The following is a description of a gene set: Binding to a neurotrophin p75 receptor. Mouse Gene Set: GOMF_NEUROTROPHIN_P75_RECEPTOR_BINDING studied in species Mus musculus, and this is the list of marker genes: Ntf3, Zfp369, Ntrk1 (neurotrophic tyrosine kinase, receptor, type 1), Ntf5, Zfp110, Nradd